The following is a description of a gene set: The cytokine scatter factor (SF) (hepatocyte growth factor) transduces various biologic actions, including cell motility, invasion, angiogenesis and apoptosis inhibition. The latter is relevant to understanding the role of SF in promoting tumor cell survival in different contexts, for example, detachment from basement membrane, growth in metastatic sites and responses to chemo- and radiotherapy. Previously, we showed that SF protects cells against apoptosis owing to DNA damage, by a mechanism involving phosphoinositol-3-kinase/c-Akt signaling. Here, we used DNA microarray assays to identify c-Akt-regulated genes that might contribute to cell protection. DU-145 human prostate cancer cells were transfected+/-a dominant-negative mutant Akt, treated+/-SF and analysed for gene expression using Affymetrix arrays. These studies identified SF-regulated genes for which induction was c-Akt-dependent vs -independent. Selected microarray findings were confirmed by semiquantitative and quantitative reverse transcription-polymerase chain reaction. We tested the contribution of four SF-inducible/c-Akt-dependent genes (AMPD3, EPHB2, MX1 and WNT4) to protection against adriamycin (a DNA topoisomerase IIalpha inhibitor) using RNA interference. Knockdown of each gene except EPHB2 caused a small but significant reduction in the SF cell protection. The lack of effect of EPHB2 knockdown may be due to the fact that DU-145 cells contain a single-mutant EPHB2 allele. A combination of three small interfering RNAs blocked most of the protection by SF in both DU-145 and T47D cells. These findings identify novel c-Akt-regulated genes, some of which contribute to SF-mediated cytoprotection. Human Gene Set: XU_AKT1_TARGETS_6HR studied in species Homo sapiens from publication Xu J, Gao M, Fan S, Meng Q, Goldberg ID, Abounader R, Ressom H, Laterra JJ, Rosen EM (PMID 17099727) Genes up-regulated in DU-145 cells (prostate cancer) expressing a dominant negative form of AKT1 upon sham-treatment for 6 h (as a control for the HGF experiments)., and this is the list of marker genes: ERF, LYST, OAS3, MX1, IFIT3, ERBIN, UBBP1, HERC5, IFIH1, SGK2, PRKAR1A, MAP2K5, ABI1, IFI6, CDC5L, PLSCR1, IFIT1, ISG15, IFITM2, U2AF2, INHBC, TCTN2, BRCA1, IRF7, SOAT1, TAT, HNRNPH1